Given this list of marker genes ILF2, CPLANE1, TBCK, RNU6-9, CAD, MDM1, LINC02058, NUP214, ATG14, MCFD2, ANKRD44-IT1, RGS3, LAMTOR5, SELENOP, DLG1, CFAP418 (cilia and flagella associated protein 418), EPB41L2, RAPGEF2, UGGT1, MAP3K20, SUZ12P1, STOX2, ZDHHC7, ATP5F1A, VTRNA1-1, XPO1, MED13, RNU6-8, CPSF6, H3P39, DDX42, CEP95, AGBL5-AS1, SLC20A2, POLR3E, PABPC4, MYNN, CLCN7, CRLF3, TOGARAM2 (NCBI Gene Id 165186), AFP, LINC00649, GORAB, FMC1, LINC01623, ANKRA2, KYNU, GDPD1, SLC25A3, RHOT1, ATP5PBP1, PNN, RNU6-1081P, PPEF1, RNU6-402P, KMT2E, MIR924HG, UBAP2L, TNRC6A, LINC00917, LINC02739, MAT1A, ITGA4, C11orf65 (chromosome 11 open reading frame 65), LGI3, RNU6-698P, RELN (reelin), TBX3, LRAT, ECT2, VTRNA1-2 (NCBI Gene Id 56663), RNF14P3, TAFA1, CWC27, PAWR, SFTPC, PRMT5-AS1, HUWE1, HJV, ACSS2 (NCBI Gene Id 55902), SNORA53, FMC1-LUC7L2, NCSTN, NARS1, AGBL5, LAMTOR5-AS1, PRMT5, ACOX1, ZBTB38, TRIM7-AS2 (NCBI Gene Id 105377769), BCL2L13, OCEL1, C2orf42, MED16, DHX16, LYRM7, UBN2, KAT7, RNU6-191P, LPP, ARMC8, IL1R1, PRMT5P1, RNU6ATAC, NOP58 (NOP58 ribonucleoprotein), GPR35, SACM1L, CTNNA1, PPP3CB-AS1, SHF, IFRD1, TIA1, RBM39, GPBP1 (GC-rich promoter binding protein 1), PLXDC1, LINC00691, ZNF106, LINC02136, C2CD5, DCBLD1, CEP76, MIR548AP, LDHA, KHDC4, PBLD, PIGG, ARPC5, PCBP2, FN1, GPR160, MAPK6, SF3A3, RNU6-661P, NEK3, ENSG00000226087, DHX36, REV1, AKAP7, XPO5, SETX, SF3B3, VTRNA1-3, HAUS6P2, SCMH1, NKTR, PGD, USB1, PABPC4-AS1, KIFC3, RNY4, COX6B1, LAMB1, PRMT5-DT, HECTD1, SERGEF, HSPA6, CCDC54-AS1, NCAPD2, EWSR1, SRRM1, SEC24B-AS1, ICE2, LIMD1-AS1, EXT2, here is a description of the gene set: Human Gene Set: KDM1B_TARGET_GENES studied in species Homo sapiens Genes containing one or more binding sites for (KDM1B) in their promoter regions (TSS -1000,+100 bp) as identified by GTRD version 20.06 ChIP-seq harmonization. from publication Yevshin I, Sharipov R, Kolmykov S, Kondrakhin Y, Kolpakov F (PMID 30445619)